Given this list of marker genes CRB2, LMNB2, C1QBP (NCBI Gene Id 708), GLA (NCBI Gene Id 2717), MAGI2 (membrane associated guanylate kinase, WW and PDZ domain containing 2), IFT172, MEFV, NR0B1, TRPC6, NPHP1, IFIH1, MARS1, LIG4, MYO1E, KIRREL1, WDR73, EMP2 (NCBI Gene Id 2013), TBC1D8B (TBC1 domain family member 8B), SERPINA1, SOX9, IFT74, NUP93, GON7, SCAPER, SMARCAL1, FOXP3, NPHS2, VPS33A, NUP205, NOP10, RMRP, SAA1, WT1, BBS12, STAT4, CEP290, COQ8B, TTC8, RAG1, TBK1, MKS1, KANK2, CFAP418, BBS10, STIM1, FGA, CEP19, SDCCAG8 (SHH signaling and ciliogenesis regulator SDCCAG8), BBIP1, NOS1AP, ZFPM2, RASA1, FN1, IL7R, DOCK11, WDPCP, SRY, SPP1, GSN, ZAP70, PLCE1, MKKS, TPRKB, TRIM32, NUP107, NPHS1, SLC35A2, NLRP3, OSGEP, PTPRO, NEXMIF, SLC17A5, IFT27, GATA3, ARHGDIA, ZNF592, BBS2, SCLT1, SAT1, PMM2, COL4A5, JAK1, NR5A1, PDSS2, SNAP29, DGKE, COL4A4, ANLN, ITGA3, BBS9 (Bardet-Biedl syndrome 9), BBS7, BBS1, LAMA5, COQ2, COQ6, PAX2, ALG1 (ALG1 chitobiosyldiphosphodolichol beta-mannosyltransferase), NUP133, VAMP7, BBS5, DKC1 (dyskerin pseudouridine synthase 1), RAG2, MAP3K1, LAGE3, MME, CHST14, SGPL1 (sphingosine-1-phosphate lyase 1), ADA, YRDC, ARL6, IRAK1, AVIL, SCARB2, NUP85, ZNFX1, BBS4, C3, PRKCD, GATA4, CHD7, LMX1B (LIM homeobox transcription factor 1 beta), CCND1, CASP10, WDR4, LZTFL1, COL4A3, LAMB2, DCLRE1C, CYBC1, TRIM8, DHX37 (NCBI Gene Id 84742), DAAM2, PUS3, NUP160, IL2RG, WWOX, TP53RK, here is a description of the gene set: Human Gene Set: HP_NEPHROTIC_SYNDROME Nephrotic syndrome studied in species Homo sapiens Nephrotic syndrome is a collection of findings resulting from glomerular dysfunction with an increase in glomerular capillary wall permeability associated with pronounced proteinuria. Nephrotic syndrome refers to the constellation of clinical findings that result from severe renal loss of protein, with Proteinuria and hypoalbuminemia, edema, and hyperlipidemia.